Given this list of marker genes Mthfr, Mthfd2, Mthfd1l, Shmt1, Mthfd1, Folr1, Tyms, Mtrr (NCBI Gene Id 210009), Aldh1l1, Ggh, Ftcd, Aldh1l2, Dmgdh, Fpgs, Slc46a1, Shmt2, Mthfd2l, Mtr, Mthfsl, Gch1, Sardh, Dhfr, Gart, Pm20d2, Aasdhppt, Atic, Mthfs, Folh1, here is a description of the gene set: Mouse Gene Set: GOBP_FOLIC_ACID_CONTAINING_COMPOUND_METABOLIC_PROCESS species: Mus musculus The chemical reactions and pathways involving a folic acid-containing compound, i.e. any of a group of heterocyclic compounds based on the pteroic acid skeleton conjugated with one or more L-glutamic acid or L-glutamate units.